Given this list of marker genes Slc30a10, Src, Car2, Prkcd, Smad3, Cav1, Map3k7, Adora2b, Mas1, Ang2, Ddr2, Ptpn1, Lrrc25, Nfe2l2, Rac1, Iqgap1, Sirt6, Rap1gds1, Rock1, Ahcyl1, Ace, Slc26a6, Agtr1a, Capn1, Fam114a1 (family with sequence similarity 114, member A1), Nr3c2, Prkca, Agt, Comt, Agtr2, Actn2, Hsf1, Rock2, Kl, Cybb, Prkcg, Agtr1b, Prkcb, Agtrap, Brip1, Ppp3ca, Camk2a, Nono, Ptgs2, Prkd1, Col3a1, Inhba, Kdm6a, Rela, Nfkb1, here is a description of the gene set: Mouse Gene Set: GOBP_RESPONSE_TO_ANGIOTENSIN studied in species Mus musculus Any process that results in a change in state or activity of a cell or an organism (in terms of movement, secretion, enzyme production, gene expression, etc.) as a result of an angiotensin stimulus. Angiotensin is any of three physiologically active peptides (angiotensin II, III, or IV) processed from angiotensinogen.